The following is a description of a gene set: Human Gene Set: GOCC_ORGANELLE_MEMBRANE_CONTACT_SITE A zone of apposition between the membranes of an organelle with another membrane, either another membrane of the same organelle, a membrane of another organelle, or the plasma membrane. Membrane contact sites (MCSs) are structured by bridging complexes. They are specialized for communication, including the efficient traffic of small molecules such as Ca2+ ions and lipids, as well as enzyme-substrate interactions. species: Homo sapiens, and this is the list of marker genes: ESYT2, MICOS10, GRAMD1C, CHCHD3, BCL2L10, AHCYL1 (NCBI Gene Id 29039), TMEM41B, CLCC1, SACM1L, TMCC1, ATG14, EIF2AK3, BLTP2, TOMM20, OSBPL1A, CANX, ZFYVE1 (zinc finger FYVE-type containing 1), IMMT, APOO, RMDN3 (NCBI Gene Id 55177), C2CD2L, VPS13A, CHCHD6, SERAC1, STX17, RAB38, GRAMD1A, PDZD8, SELENON, ATAD3A, STARD3NL, FATE1, MBOAT7, RAB32, BCAP31, TOMM40, MICOS13, ATG2A, ESYT3, CLSTN3, TMX1, TMX2, PIK3R4, STIMATE, ATG5, OSBPL5, APOOL, STARD3, GRAMD1B, SARAF, MOSPD2, MICU1, BLTP1, GRAMD2A, ATG16L1, ACSL4